Given this list of marker genes ADAR, AICDA, HMCES, MCM3AP, POLM, MSH6, EXO1, POLL, SAMHD1, MSH2, POLQ, MLH1, UNG, PMS2, POLB, here is a description of the gene set: The process in which immune receptor genes are diversified through somatic mutation. species: Homo sapiens Human Gene Set: GOBP_SOMATIC_DIVERSIFICATION_OF_IMMUNE_RECEPTORS_VIA_SOMATIC_MUTATION